Given this list of marker genes HK2, MAML3, ABLIM3, WNT3, CAVIN1, CNTD1, NDE1, GBF1, RNF25, SMOX, ERG, BCKDHA, LTBP1, SYNCRIP, XRCC5, PAX8, PDE10A, CIART, DLX3, HIGD1A, NR2F2, SP7, ARID1B, PEX16, SFN, RBMX, HPSE2 (NCBI Gene Id 7354), WNT6, NDST4, UCMA, STAT3, ANKRD12, HIF1A, CALD1, PGRMC2, TLX1, POU6F2, FNBP1L, SPARCL1, AKAP1, H3C8, CDK19, FGF13, HDX, EFCAB12, PDP1, FAM110A, COL1A1, ASCL2 (achaete-scute family bHLH transcription factor 2), LAMC2, ERH, MANEA, ANGPT1, OS9, SESN2, NGFR, HAS2, KMT2E, C3orf18, STK10, CBX8, MID2, ABCD2, TSNAXIP1, PRICKLE3, HLA-DOA, HMGA2, ZNF32, TMEM132A, IER5L, CACNA1E, CDC42EP4, KLF1, STMN1, NTRK2, AJUBA, TMEM31, KANSL1L, NOL3, PCYT2, JMJD1C (NCBI Gene Id 9323), CLASP1, HEPH, PHF1, NKD1, TCF4, ELAVL3, PHF20L1, BRD2, HOXA9, GFRA1, PAX2, STARD4, ZNF385A, IMPDH2, C21orf58, NOSTRIN (NCBI Gene Id 115677), PIK3IP1, MN1, TLL2, PCNA (proliferating cell nuclear antigen), CXXC5, ARL6IP6, NADK2, ASPHD1, HEPACAM, SP8 (NCBI Gene Id 378050), ENHO, FOXP1, RNF133, ELP6, ATP1B1, PDIA3, MRFAP1, MYT1, PRX, RORA, XPO1 (exportin 1), OLIG1, PTMS, NR2F6, DNAJA2, FAM83D, DPP10, SHLD2, SBF2, TAF15, CDK16, CYP26A1, DEPTOR, H2BC21, RAB5B, ZEB2, RBP3, DAZL, SEPTIN3, MTRFR, MORN4, KPNB1, CATSPER2, POU3F4, NAT8L, RND1, ACACA, SRSF6 (NCBI Gene Id 6431), GPHN, OSBPL5, BAG4, MACROD1, LHX5, TBX5 (NCBI Gene Id 6910), KLF7, VSX2, DLEU1, RNF152 (NCBI Gene Id 220441), HES1, SKA2, HNRNPR, VIM, HMBOX1, CDKL5, KLF11, PDXP, CCDC80, CTNND1, ZBTB3, ISL1, NR2C2, ADNP2, ARID1A, DLX2, YJU2B, CDC25C, ZIC2, PCNT, AFF3 (NCBI Gene Id 3899), ZNF516-DT, SEMA5B, NUBP2, SERTAD3, NOS3 (NCBI Gene Id 4846), CLC, HTN1 (NCBI Gene Id 3346), HHEX, FRY, LRP5, H2AC20, TLX3, ELOVL5, VCAN, NDUFB3, IST1, DNAJC12, NRXN1, GBA2, STAC2, WNT2, SLC26A2, RAB5IF, ILDR2, PTF1A, ANP32A, SLC37A4, MAP3K3, FBXO28, PRR11, SLC39A4, TNFSF12-TNFSF13, CALM2, PCYT1B, ADRB1, PPP2R5D, GSTO2, NEK10, ELAVL4, MYRF, USP9X, CHFR, DIXDC1, MEIS1, WDR47, PCDH17, ETAA1, TLE1, DLG3, CHKA, MYOCD, CDH1, NOTCH3, TEAD3, USP3, ESRRB, LINC02875, DDX4, SCRT2, WBP1, SSBP3, HNRNPC, MAN1C1, TDRD5, APC2, MTSS1, TDO2, HNF4A (hepatocyte nuclear factor 4 alpha), HOXB8, SLC25A28, ADAMTS10, H2BC10, NKX6-1 (NCBI Gene Id 4825), EEF1DP3, SLC11A2, RBM48, ZNF282, RANBP10, KCND3, GLUD1, KLHL34, PLA2G3, PRELP, SUCO, SIAH3, PARD6G, DHCR24, TXLNG, GTF2A1, TMEM143, SLC44A5, MEOX1, TMCC3, MORF4L2, VAX1, PHC1, ABCA7, TEAD2, RERE, TNFSF12, RUNX1T1, SLC25A25 (solute carrier family 25 member 25), CAPN6, WNT8B, ZMYM2, HOMEZ, GFI1B (NCBI Gene Id 8328), EBF1 (NCBI Gene Id 1879), PCDHGC3, SLC25A4, NTN1, SPACA9, RP2, SORBS2, HYCC2, HDAC9, RAPGEF6, PITPNC1, ATCAY, HEY1, HMGB1, ZSCAN20, HOXA2, ZBTB10, TAOK2, TSC22D1, PSME3, RAB39A, CYP4F12, SOX10, CRX, GOLGA8IP, SYNGR4, HOXA1, PSMA3, MRPL50, FAM193B, CHD6, SELENOK, PCDH20, PHF21A, ZNF532, PDZD7, NRP1, MEX3B, CWF19L1, EPC2, AK8, SLC4A7, FAR1, LRRIQ1, SWT1, MCF2, ZEB1, C1S, GPR85, GFOD2, SLC25A35, HERPUD1, LRRN1, MLEC, LMAN2L (lectin, mannose binding 2 like), CNOT1, PEX1, STON1-GTF2A1L, NANS, SMAD6, ID4, GJD2, KGD4, YWHAQ, NDP, SLC39A9, UBE4B, FRAS1, ARHGAP33, HCRT, PALM, TFAP2D, EEF1E1 (NCBI Gene Id 9521), BTBD9, H2BC1, SCRG1, SEMA3A, HOXD4, UBE2C, ZDHHC5, RPS3, LCOR, STMN4, GATM, ADNP, ZBTB9, TSPYL2, MAEL, WBP2, INTS9, TSPAN5, TRAF4, RMND5A, BMP6, NXN, H3-3B, RAB3C, LSM1, ETFA, SEPTIN4, ELMO1, CRABP2, AKIRIN2, TRIB2, ZNF362, SEMA4C, FOXP2 (forkhead box P2), CSPG5, H2AC21, RAD54L, DLGAP4, PHACTR3, RBM14, DMD, TOM1, PHOX2B, SORT1, DPYSL5, LPCAT3, WNT1 (Wnt family member 1), MDFI, PPFIA2, BCOR, OTX2, HERC2, TBXT, ATOSB, RALYL, GGNBP2, CACNA1G, NR1D1, PNN, TP63, CNN3, MEX3C, ZNF189, PPARG, BRICD5, DUSP6, MYCL, RAB1A, KCNH2, DACH2, NFIB, ZMYND8, ARID4A, ACAA2, ARAP1, CDKN1B, MRPS30, GRIA3, LINC01567, DAB2IP, HOXC6, ADAMTSL1, COA3, SOSTDC1, SIK2, IFIH1, CPT1A, AR, FERD3L, TRMT1L, TANK, MACROD2, RCOR1, NIPBL, YIPF3, PPP2R2B, ADGRA2, CPLX2, CRB2, TPM1, PIK3R3, SLC41A1, ADGRL3, TIAM1, SLC25A13, DLEU2 (deleted in lymphocytic leukemia 2), THAP9, CDKN1A, CADM2, NCAM1, CIC, SF1, LENG1, RAP2B, MNT, TGFB3, COMMD10, FST, SLIT3, WSB1, YPEL4, TSGA10, POGZ, STK36, PSMB3, SMIM12, NIPAL3, SPCS2, RASSF2, REPS2, SRSF2, ANKS1B, SIX1, CDH10, DACT3, MASP1, IBSP, BAHD1, TMEM125, H2AC1, PIK3R1, STARD3, CRYL1, SERPING1, YIF1A, JDP2, EMID1 (NCBI Gene Id 129080), CALU, HOXA10, COQ10B, LMO3, EOMES, CLDN17, CD74, SLC16A11, HBA2, BACH2, ACVR1, SP140L, CCER1, SLC25A10, ANKRD11, CHST8, here is a description of the gene set: Genes having at least one occurrence of the highly conserved motif M46 WTTGKCTG in the regions spanning 4 kb centered on their transcription starting sites. The motif does not match any known transcription factor binding site. species: Homo sapiens Human Gene Set: WTTGKCTG_UNKNOWN from publication Xie X, Lu J, Kulbokas EJ, Golub TR, Mootha V, Lindblad-Toh K, Lander ES, Kellis M (PMID 15735639) Comprehensive identification of all functional elements encoded in the human genome is a fundamental need in biomedical research. Here, we present a comparative analysis of the human, mouse, rat and dog genomes to create a systematic catalogue of common regulatory motifs in promoters and 3' untranslated regions (3' UTRs). The promoter analysis yields 174 candidate motifs, including most previously known transcription-factor binding sites and 105 new motifs. The 3'-UTR analysis yields 106 motifs likely to be involved in post-transcriptional regulation. Nearly one-half are associated with microRNAs (miRNAs), leading to the discovery of many new miRNA genes and their likely target genes. Our results suggest that previous estimates of the number of human miRNA genes were low, and that miRNAs regulate at least 20% of human genes. The overall results provide a systematic view of gene regulation in the human, which will be refined as additional mammalian genomes become available.